The following is a description of a gene set: Genes having at least one occurrence of the motif NNGAATATKCANNNN in the regions spanning 4 kb centered on their transcription starting sites. This matches the POU2F1 transcription factor binding site V$OCT1_02 (v7.4 TRANSFAC). studied in species Homo sapiens Human Gene Set: OCT1_02, and this is the list of marker genes: PTPRN, MYH4, LPL, TGIF1, PHF21B, DYNLT5, TENM1 (NCBI Gene Id 10405), ZHX1, FUT8, AHCY, FGF13 (fibroblast growth factor 13), MAML3, FZD8, WDR12, THRA, GPBP1, BLCAP, SLC25A35, LRRN3, PFKFB1, RAB10, ADAMTSL1, COMMD10, PKNOX2, ACVR1C, FOXP1, TRPC4, ENTPD1, NRK, MARCHF10, KCNJ13, RNF2, SEMA3A, OTP, ZNF521, MAP2 (microtubule associated protein 2), POLR3F, ZBTB20, RASGEF1B, NSMCE3, NECAP1, GPR17, CARF, ZNF428, SMARCA2, TMSB4XP4, GABARAPL2, PIK3R3, GAP43, LTBP1, PCDHGA1, TMEM131L, HCN4, HOXC11, PAX2, LIX1, PAX6, ERBB4, ZIC4, ZIC2, DCN, NPM3, CHRDL1, CACNA1D, NKRF, KCNIP4, TET2, DZANK1, COL9A1, HFM1, SDHC, HDAC9, REST, PCSK2, SDCCAG8, DIP2B, ELAVL4, GNAL, PHLPP1, SEPHS1, FES, CDKN2C, ZBTB32, TCEAL1, DNAH9, MBNL1, PDE1A, PURA, TSHB, LINC01597, CHCHD7, RGS8, TAFA1, ARPC5, ZIC1, TNNI3K, PRDM8, UBE4B, CDX2, STC1, DTNA, CHML, VGLL3, JAG1, NRXN3, NFIA, PDE4D, IQUB, OMG, ZBTB4, DMD, LINC00052 (NCBI Gene Id 145978), NPAS3, PTF1A, SIAH3, ZNF385B, AFF3, PHOX2B, FOXP2, KRTAP8-1, KIRREL3-AS3, YWHAB, CNTN6, PDZRN4, ESRRG, HOXA10, COLCA1, GFOD1, TRPS1, C8orf17, LOX (lysyl oxidase), OTOS, HOXC5, TYRO3, DLX1, DDX17, SULT2A1 (sulfotransferase family 2A member 1), TCF4, TMEM88, RUNX1T1, POLR2A, OR10J1, TSC1, HMGB2, ARPP21, TDRD5, TMSB4XP8, SKP1, PRL, BUB3, CCDC91, BCL2L1, KCNN3, CPNE1, RPS19, TMSB4XP6, TBR1, CSNK1A1L, HIC2, CEP41, CSMD3, ATF7IP, PLAG1, HORMAD2, FGFR1, AR, GSC, RGL1, DMRTB1, MEIS1, CEP120, INSM1, CACNA1C, TRDN, GAL3ST1, TIAL1, ANK3, KIRREL3, BNC2, PTPRJ, THRB, RUNX1, ARHGAP6, PPARGC1A, ITGAL, HOXB1, ZNFX1, DCX, GABRG2, POU2F1, DSCAM, DPYSL2, DLG2, NPTX2, NHLH1, DAAM1, ANKRD1, POU4F2, ASPM, BCO2, CREB3L1, PPFIA2, PHKA2, FNBP4, IL1RAPL1, OLIG3, JAM3, HS3ST4 (NCBI Gene Id 9951), GPC3, PRKRIP1, DLGAP4, CXCL14, DNAJA4, DOC2A, TUT1